The following is a description of a gene set: studied in species Homo sapiens Human Gene Set: HP_DECREASED_CALVARIAL_OSSIFICATION Abnormal reduction in ossification of the calvaria (roof of the skull consisting of the frontal bone, parietal bones, temporal bones, and occipital bone). Decreased calvarial ossification, and this is the list of marker genes: INTU, PPIB, COL1A2, FGFR2, FIG4, PPP3CA, IFT43, ZMPSTE24, P3H1 (prolyl 3-hydroxylase 1), SERPINH1, CRTAP, ALPL, CREB3L1, COL1A1, LAMA5, WNT7A, TXNDC15 (NCBI Gene Id 79770)